The following is a description of a gene set: studied in species Homo sapiens The breakage of covalent bonds to detach lipid groups from a protein. Human Gene Set: GOBP_PROTEIN_DELIPIDATION, and this is the list of marker genes: ATG4B, ATG4D, ATG4A, ATG4C, SIRT6